Given this list of marker genes HMGCL, GABRR1, AMZ2, ZNF662, SLC52A1, REN, GFI1B, MYO16, OLFM4, PCDHB19P, CCL8, ZNF32-AS3, IGKC (immunoglobulin kappa constant), MOCOS, TBX1, ENSG00000255428, GPHB5, NIBAN1 (niban apoptosis regulator 1), AMELX, CLUL1, B9D2, DNAAF5, INTS10, SLC45A2, NDEL1, SSH3, IGSF6, ZNF664, COPS9, ITIH3, TMEM185B, HTR5A, SPOCD1, DAOA, REPIN1, ADH6, FOSL2-AS1, FZD9, CHMP4A, LRRC3, S100Z, TECRL, RSPH4A, EHF, XRCC5, KLHL13, CCDC86, ATP5ME, SNHG1, KAT6A, PROS1, BTBD8, HDDC3, SCO1, CBY1, TNFRSF8, BCDIN3D-AS1, ANKRD30A, ERN2, SURF6, RNF2, ZNF276, PCED1B-AS1, TRAPPC4, SRXN1, DNAH1, GPR89A, PLSCR2, RPL36AL, LTA, MRPL51, KRT38, SPEF1, NHLH1, ZNF473CR, DCTN1-AS1, IL22RA1, GLYAT, VIRMA, NTRK1, HAVCR2, SHD, SLC5A12, GBP6, C3orf62, ANKRD24, ATP2B1-AS1, ZFP62, LINC01600, MARVELD1 (MARVEL domain containing 1), EML6, SMO, C2orf42, RPPH1, NVL, RILPL1, LENG9, PP2D1, ALKBH4, ZC4H2, WNT9B, RGS1, LYSET, TSPEAR-AS1, SCRT1, MRPS21, CPS1-IT1, ETNPPL, ZAN, CALU, ZCWPW1, TOE1, MRPL20-AS1, VAMP5, CYP2W1, SNX22, LAMP1, FRMPD1, PTPRJ, SESN1, FAM184B, TREH, ECHDC3, GPLD1, C15orf62 (NCBI Gene Id 648327), CD36, DHX37, ITGB1BP2, DDIT4L, CACNA1I, TRPV4, DGCR6L (NCBI Gene Id 89178), CSRP3, ARSK, LEPROTL1, PIP5KL1, CUTALP, BTN1A1, IFT88, PPIA (peptidylprolyl isomerase A), FABP6, TRIM9 (NCBI Gene Id 23206), MTLN, XPO6, NAT8, TLE3, TMEM220, PAQR4, SNORD8, GALNTL6, IL17B, AGAP11, CHST5, KIAA1210, HEXB, HCAR3, MEST, CEBPE, NDUFS4, CFAP73, TAFA2 (TAFA chemokine like family member 2), EOLA2 (endothelium and lymphocyte associated ASCH domain 2), OXLD1, SPMIP2, SENP2, NSD2, GCC1, U2AF1L4, MRPS5, RFLNB, ESD, PPP4R1, ANAPC15, FOXE3, SLCO5A1, NDRG1, EEF2KMT, ADGRD1, SLC26A1, FABP2, COMMD6, SEL1L2, DUSP26, TCEAL4, NPR2, UPP1, here is a description of the gene set: studied in species Homo sapiens Genes up-regulated in double positive thymocytes from OT-2 transgenic mice: control versus injected with agonist peptide. Human Gene Set: GSE26488_CTRL_VS_PEPTIDE_INJECTION_OT2_THYMOCYTE_UP from publication Kasler HG, Young BD, Mottet D, Lim HW, Collins AM, Olson EN, Verdin E (PMID 21398603) Abstract of publicaton: CD4/CD8 double-positive (DP) thymocytes express the transcriptional repressor Histone Deacetylase 7 (HDAC7), a class IIa HDAC that is exported from the cell nucleus after T cell receptor (TCR) engagement. Through signal-dependent nuclear export, class IIa HDACs such as HDAC7 mediate signal-dependent changes in gene expression that are important to developmental fate decisions in multiple tissues. We report that HDAC7 is exported from the cell nucleus during positive selection in thymocytes, and regulates genes mediating the coupling between TCR engagement and downstream events that determine cell survival. Thymocytes lacking HDAC7 are inefficiently positively selected due to a severely shortened lifespan and exhibit a truncated repertoire of TCR Jalpha segments. The expression of multiple important mediators and modulators of the response to TCR engagement is altered in HDAC7-deficient thymocytes, resulting in increased tonic MAP kinase activity that contributes to the observed loss of viability. Remarkably, the activity of Protein Kinase D, the kinase that mediates nuclear export of HDAC7 in response to TCR signaling, is also increased in HDAC7-deficient thymocytes, suggesting that HDAC7 nuclear export governs a self-sustaining auto-excitatory loop. These experiments add to the understanding of the life/death decision in thymic T cell development, define a novel function for class IIa HDACs, and point to a novel feed-forward mechanism whereby these molecules regulate their own state and mediate stable developmental transitions. Title of manuscript: Nuclear Export of Histone Deacetylase 7 During Thymic Selection Mediates Immune Self-tolerance. abstract of manuscript: Histone Deacetylase 7 (HDAC7) is a TCR signal-dependent regulator of differentiation that is highly expressed in CD4/CD8 double-positive (DP) thymocytes. Here we examine the effect of blocking TCR-dependent nuclear export of HDAC7 during thymic selection, through expression of a signal-resistant mutant of HDAC7 (HDAC7-delta-P) in thymocytes. We find that HDAC7-delta-P Transgenic thymocytes exhibit a profound block in negative thymic selection, but can still undergo positive selection, resulting in the escape of autoreactive T cells into the periphery. Gene expression profiling reveals a comprehensive suppression of the negative selection-associated gene expression program in DP thymocytes, associated with a defect in the activation of MAP kinase pathways by TCR signals. The consequence of this block in vivo is a lethal autoimmune syndrome involving the exocrine pancreas and other abdominal organs. These experiments establish a novel molecular model of autoimmunity and cast new light on the relationship between thymic selection and immune self-tolerance. Goal of Microarray experiment: We did these experiments to determine how alteration of the function of HDAC7, a site-specific and signal-dependent repressor of transcription, changes gene expression in CD4/CD8 DP thymocytes.